Given this list of marker genes DOLK, here is a description of the gene set: species: Homo sapiens part of: Diseases associated with glycosylation precursor biosynthesis Dolichol kinase (DOLK, TMEM15) normally mediates the phosphorylation of dolichol (DCHOL) to form dolichyl phosphate (DOLP) in the ER membrane. DOLP is an important substrate in the synthesis of N- and O-glycosylated proteins and GPI anchors. Defects in DOLK cause congenital disorder of glycosylation type 1m (DOLK-CDG, CDG1m, also known as dolichol kinase deficiency; MIM:610768), a severe mutisystem disorder characterised by under-glycosylated serum glycoproteins. This disorder has a very severe phenotype and death can occur in early life. Reactome Pathway: Defective DOLK causes DOLK-CDG